Given this list of marker genes CTSB, COL11A1, COL1A1, TMPRSS6, COL5A2, COL23A1, COL6A3, COL12A1, COL2A1, COL9A1, COL11A2, MMP15, COL9A3, FURIN (furin, paired basic amino acid cleaving enzyme), COL25A1, COL5A1, COL6A5, MMP10, COL13A1, COL4A4, COL9A2, MMP7, MMP19, MMP9, COL3A1, COL6A6, COL10A1, CTSL, COL16A1, COL17A1, COL8A1, PRSS2, MMP20, COL15A1, COL14A1, COL19A1, MMP11, COL26A1, MMP3, COL6A2, CTSK, MMP1, COL4A1 (NCBI Gene Id 1282), COL1A2, COL4A3, MMP2, MMP12, PHYKPL, MMP13, COL7A1, COL4A2, COL18A1, ADAM17, COL8A2, ADAM9, COL4A5, COL4A6, ADAM10, MMP14, COL6A1, ELANE, COL5A3, MMP8, CTSD, here is a description of the gene set: species: Homo sapiens part of: Degradation of the extracellular matrix Reactome Pathway: Collagen degradation Collagen fibril diameter and spatial organisation are dependent on the species, tissue type and stage of development. The lengths of collagen fibrils in mature tissues are largely unknown but in tendon can be measured in millimetres. Collagen fibrils isolated from adult bovine corneal stroma had ~350 collagen molecules in transverse section, tapering down to three molecules at the growing tip (Holmes & Kadler 2005). <br><br>The classical view of collagenases is that they actively unwind the triple helical chain, a process termed molecular tectonics, before preferentially cleaving the alpha2 chain followed by the remaining chains. More recently it has been suggested that collagen fibrils exist in an equilibrium between protected and vulnerable states. The prototypical triple-helical structure of collagen does not fit into the active site of collagenase MMPs. In addition the scissile bonds are not solvent-exposed and are therefore inaccessible to the collagenase active site. It was realized that collagen must locally unfold into non-triple helical regions to allow collagenolysis. Observations using circular dichroism and differential scanning calorimetry confirm that there is considerable heterogeneity along collagen fibres allowing access for MMPs at physiological temperatures.<br><br>Collagen fibrils with cut chains are unstable and accessible to proteinases that cannot cleave intact collagen strands (Woessner & Nagase 2000, Somerville et al. 2003). Continued degradation leads to the formation of gelatin. Degradation of collagen types other than I-III is less well characterized but believed to occur in a similar manner. <br><br>Metalloproteinases (MMPs) play a major part in the degradation of several extracellular macromolecules including collagens. MMP1, MMP8, and MMP13, sometimes referred to as collagenases I, II and III respectively, are able to initiate the intrahelical cleavage of the major fibril forming collagens I, II and III at neutral pH, and thus thought to define the rate-limiting step in normal tissue remodeling events. All can cleave additional substrates including other collagen subtypes. Collagenases cut collagen alpha chains at a single conserved Gly-Ile/Leu site approximately 3/4 of the molecule's length from the N-terminus. The cleavage site is characterised by the motif G(I/L)(A/L); the G-I/L bond is cleaved. In collagen type I this corresponds to G953-I954 in the Uniprot canonical alpha chain sequences (often given as G775-I776 in literature). It is not clear why only this bond is cleaved, as the motif occurs at several other places in the chain. MMP14, a membrane-associated MMP also known as Membrane-type matrix metalloproteinase 1 (MT-MMP1), is able to cleave collagen types I, II and III.